Given this list of marker genes RFK, TPK1, SLC19A2, SLC25A19, PSAT1, PNPO, THTPA, SLC19A3, PDXK, here is a description of the gene set: species: Homo sapiens Human Gene Set: GOBP_WATER_SOLUBLE_VITAMIN_BIOSYNTHETIC_PROCESS The chemical reactions and pathways resulting in the formation of any of a diverse group of vitamins that are soluble in water.